The following is a description of a gene set: Photodynamic therapy-induced HIF-1 survival signaling Human Gene Set: WP_PHOTODYNAMIC_THERAPYINDUCED_HIF1_SURVIVAL_SIGNALING studied in species Homo sapiens, and this is the list of marker genes: PTGS2, BNIP3L, BNIP3, BID, NOS2, TGFB3, LDHA, BAK1, ANGPT2, PGK1, BIRC5, EGLN1 (egl-9 family hypoxia inducible factor 1), ADAMTSL4-AS1, PDHA1, BCL2A1, VEGFA (NCBI Gene Id 7422), BCL2L1, HK1, TGFA, ANGPT1, SERPINE1, SLC16A1, SLC2A1, EPO, BAX, SLC2A3, IGFBP2, MCL1, PFKL, HIF1A (hypoxia inducible factor 1 subunit alpha), IGFBP1, HIF1AN, IGFBP3, PKM, TP53, ARNT, PMAIP1, EDN1